The following is a description of a gene set: Ventriculomegaly Human Gene Set: HP_VENTRICULOMEGALY An increase in size of the ventricular system of the brain. studied in species Homo sapiens, and this is the list of marker genes: IGF2, SCO2, TOE1, DNAH1, MARS2, D2HGDH, TMTC3, WDR26, SMC1A, LSM11, LMNB1, TBC1D24, DEAF1, XRCC2, DPH1, SEC31A, CTNNB1, TRIP13, ZNF292, GON7, TUBB2A (NCBI Gene Id 92919), UBE3B, BRCA2, KIAA0753, IDH1, RAD51, SPRED2, SHANK3, BMP4, PLAA, MAB21L1, NPHP3, RPGR, WASHC5, C12orf57, ACTA2, CDC42, NDN, ATP11A, GFM2, CCDC39, CSGALNACT1, TAOK1, COASY, CLCN3, POLR1A, SLC31A1, SIM1, WLS, PCDH19, HRAS, CASK, GAS2L2, NCAPD3, FANCC, DNAAF1, FBXO28, TUBG1, SPEN, NDE1, GRIA3, TRIM71, ATP6V1B2, PTCH1, FBN1, TAF6 (TATA-box binding protein associated factor 6), AKT3, WDR73, FGFRL1, KCNQ1OT1, SMARCC2, TAF8, TBC1D2B, NHLRC2, EIF4A2, RNU4-2, ODAD4, RAD21 (NCBI Gene Id 5885), PUM1, OSGEP, PMM2, SNORD115-1, TET3, RNASEH2B, SATB1, FLII, USP18, NCAPG2, ERCC4 (ERCC excision repair 4, endonuclease catalytic subunit), ASPM, CEP152, PIGB, CHD7, FGFR3, CCNO, TMEM237, SLC20A2, HTRA2, CARS1, TIMMDC1, LETM1, SHH, ZBTB20, NAXE, PRNP, SOX9, EXT1, DAG1, TGDS, L1CAM, IFT140, AHI1, FH, CYFIP2, JAM2 (NCBI Gene Id 58494), KLHL15, SIN3B, ATP6V1E1, SON, SMG9, FARS2, GABBR2, NFIA, COG8, INTU, IQSEC2, SMARCB1, FOXF1, SPAG1, TRAPPC10, STAC3, CC2D2A, PIK3CA, ZMIZ1, RXYLT1, FKTN, SOX4, SLC32A1, EIF2B5, DPYSL5, RNF113A, OFD1, PIGA, NFIB, MID1, B4GALT1, DHCR7, ERCC3, MEF2C, POMGNT1, YARS1, CFAP74, C2CD3, ODAD3, FLVCR2, AHCY, HERC1, B9D1, NIPA2, NME8, NRCAM, RAD51C, SPG11, METTL5, HSPG2, VPS37A, HYDIN, PDGFRB, SLC9A6, POLRMT, NAXD, MBTPS2 (membrane bound transcription factor peptidase, site 2), FANCG, BCOR, TSEN2, DNA2, ODC1, KDM6A, PUF60, TXNDC15, NEK1 (NIMA related kinase 1), YME1L1, KRT5, CASZ1, NSD2, DHX9, FANCB, MCPH1, SMC3, ERCC2, COG1, ERCC8, ASXL3, POLR3A, DNAI2, FANCE (FA complementation group E), RAB3GAP2, PSAT1, TSEN54, BCAP31, LAMA1, RPGRIP1, KANSL1, RSPH4A, DKC1, TSFM, HTT, GJB2, INTS11, ABCD1, KCTD1, PMPCA, PUS7, CHD4, APC2, PSAP, TMX2, PI4KA, FANCM, ROGDI, CELF2, MAD2L2, PLOD3, DYNC2I1, DCHS1 (dachsous cadherin-related 1), TTC5, FIG4, IFIH1, PAX6, LIPT2, NDUFB11, COPB2, PPP2R1A, RPS6KA3, PHGDH, NDUFS2, GNAO1, EZH2, ANKRD11, NRAS, RAB18, TBK1, KRT14, EHMT1, MTHFS, HNRNPK, RAI1, FGFR2, TSEN34, MAGEL2, TRPS1, GCDH, GLB1, ZNF462, CFAP298, BLTP1, HDAC8, ACD, GJB6, DHCR24, MYMX, GOSR2, EBP, KAT8, CPT2, TCTN3, CEP290, PAFAH1B1, CTSF, RNU4ATAC, TUBB3, MPDU1, TAPT1, RTTN, GRM1, TNFRSF11A, DOK7, IFT43, SV2A, ATP1A1, TMEM138, SETD2, UBE2T, TSEN15, MYCN, MCM7, PDHX, SLC25A19, CEP63, MTOR, SEPSECS, KANK1, SASS6, ZNF148, MINPP1, ERCC5, OTUD6B, TAF13, SPEF2, NDST1, VPS13A, STRADA, KIDINS220 (NCBI Gene Id 57498), COL4A1, MAST1, PIGQ, PLCH1, LUZP1, BUB1B, RAP1B, WARS1, ACTB, TMEM216, MCIDAS, COX16, HECW2, PYCR2, POMK, WDR45B (WD repeat domain 45B), MSL3, INPP5E, GLI3, NIPBL, IFT80, ESCO2, TRAF7, GRIN1, NAE1, SIN3A, KIF26A, NSD1, ZIC1, KCNN2, SMO, KNSTRN, SHMT2, ARX, RAC3 (Rac family small GTPase 3), BRIP1, TARS1, YIPF5, POGZ, GRIK2, PI4K2A, HIBCH, ATP6V0A2, MAX, SOX11, BRF1, PRDM16, COG5, ZIC2, CCDC174, CHD8, DNMT1 (NCBI Gene Id 1786), SETBP1, DNAH9, CRB2, PLG (NCBI Gene Id 90749), TNPO2, BMP2, AMPD2, YY1, GMPPB, SUCLA2, CENPE, TERT, GTF2E2, OSTM1, DPF2, EBF3, LMNB2, USP9X, MKRN3, MYORG (NCBI Gene Id 57462), PWAR1, SLC35A2, TRPM3, ATXN3, TNNI3, RPGRIP1L, IFT172, SUMF1, NIPA1, FANCL, ALG12, COG6, TUBA1A, THOC2, OGDH, LRRC32, ZBTB11, B3GALNT2 (NCBI Gene Id 148789), NAA80, CDK10, ALDH6A1, DYRK1A, UBTF, NPAP1 (nuclear pore associated protein 1), FBXL4, PDE2A, GLUL, SARS1 (seryl-tRNA synthetase 1), OCLN, FOXP3, ARID1A, WAC, NME5, SHQ1, TRAPPC12, TAF1, POLR2A, MRE11, MTM1, KCNJ6, NAA10, COX6B1, RNU12, RERE, CEP57, BRCA1, CUX1, EVC2, OCRL, PTEN, HUWE1, DNAAF2, GNB2, KCNAB2, ADAR, TYROBP, B9D2, PTDSS1, DNAI1, DNAL1, LARGE1, ADGRG1, VPS53, TBL1XR1, GTF2H5, ZMYND10, ASXL2, COL18A1, TRPV6, ATP6AP2, TPRKB, KMT2C, KRAS, KIF5A, LONP1, HYLS1, FTO, AARS2, MTHFR, DPM1, DNMT3A, SMARCA4 (NCBI Gene Id 6597), CFAP300, CLXN, WDR81, CCDC88A, ARID2, ZEB2, DNAAF4, DENND5A, DRC1 (NCBI Gene Id 92749), NUP37, EXOC2, NDUFA6, RAPSN, CDK5RAP2, KPNA3, ESAM, GPC3 (glypican 3), KIFBP, KIF7, VPS11, PARN, KMT2D, CPLX1, SLC12A6 (solute carrier family 12 member 6), CCDC88C, RNF125, DNAH11, CHST14, ITPR1, TTC12, MAF, TCTN1, DNAJB13, SLC18A3, PUS3 (NCBI Gene Id 83480), MOCS1, RNASEH2A, KNL1, RRAS2, SLITRK2 (SLIT and NTRK like family member 2), ODAD1, VSX1, KIF21A, SPTBN1, PIK3R2, ATXN1, DMPK, PHC1, OPHN1, HK1, DSE, CDK6, GABRD, MED12, DTYMK, ANKLE2, EMG1, PNKP, USP7 (NCBI Gene Id 7874), BUB3, COX20, PGAP3, FOXJ1 (forkhead box J1), CCDC40, KATNB1 (katanin regulatory subunit B1), MT-ATP6, DNAAF3, ZC4H2, RTEL1, ERCC6, KCNQ1, COL3A1, TUBB2B, FBP1 (NCBI Gene Id 2203), KMT5B, HSD17B4, FANCD2, PPFIBP1 (PPFIA binding protein 1), NADK2, CTBP1, CILK1 (NCBI Gene Id 51541), ADNP, ZNF699 (NCBI Gene Id 374879), BRD4, BUB1, TINF2, MOCS2, COL4A2, HS6ST2, VPS35L, ISCA1, NEXMIF, H1-4, DIAPH1, RSPH1, H3-3A, RNASET2, CDC42BPB, TRAPPC6B, TBCD, NEK10, MYOD1 (myogenic differentiation 1), CEP135, SKI, TCTN2, GRN, TMEM231, AARS1, KCNK4, CUL4B, FKRP, MED25, TRAIP, XRCC4, RSPH9, DDX3X, CTCF, SHPK, ODAD2, TCF4, ALG8, PGAP1, KPTN (kaptin, actin binding protein), ZSWIM6, MRPS16, PPP2R5D, SNRPN, CHD3, RAB11B, DNAAF5, POMT1, TUBB, VRK1, FANCA, AP4B1, AFG2B, AP1S2, PPP1R21, PIGN, WBP4, TREM2, MAPRE2, PRKCZ, PIEZO2, ALG2, PIGO, PWRN1, SAMHD1, CFAP221, MMP23B, LIPT1, CIT, ZNF335, CDKN1C, FBXW11, MYT1L, FAT4, IBA57, SLC25A1, RSPH3, FLI1, MAG, TMEM147, RAC1, DPH2, MYMK, ZNHIT3, DCX, PLPBP, FANCF, YWHAE, NFIX, PDHA1, PGAP2, NDUFA8, RNF213, DHX30, PCNT, TREX1, SLC39A8, RAB3GAP1, PPP2CA, EML1, XPR1, ATXN2, EOMES, SMARCD1 (SWI/SNF related, matrix associated, actin dependent regulator of chromatin, subfamily d, member 1), ALG3, DNM1, RNASEH2C, ARMC9, SH2B1, TBCK, IFT56, SEMA3E, ASXL1, DYNC2H1, WDR35, NUP88, OCA2, MPLKIP, CSF1R, CEP120, B3GLCT, EVC, GPSM2, FOXRED1, GAN, SLX4, AP4E1, ROBO1, MFSD2A, POMGNT2, PHACTR1, DOCK6, NOTCH2NLC, SLC6A9, CLTC (clathrin heavy chain), ATP6V1A, NDUFS8, TRAPPC14, GET4, WASF1, TMCO1, BICD2, VPS51, ATP1A3, STK36, TRRAP, ALDH7A1, GPC4, ACTG1, STIL (NCBI Gene Id 6491), COX8A, PDGFB, MPDZ, NUP188, GBA1, CSPP1, DNAAF6, DNAAF11, HERC2, CLCN4, RFWD3, ANTXR1, WARS2, PDPN, DLL1, PDHB, MUSK, SMARCE1, TMEM67, PPP1CB, NANS, AHDC1, CTDP1, BGN, B4GAT1, UBE4B, CCDC22, QARS1, POMT2, CCND2, ALPK3, DOHH, UGDH, SMAD2, SRPK3, TMEM107, HEPACAM, TRIM37, SNIP1, MAPKAPK5, ARHGAP31 (NCBI Gene Id 57514), MAN2C1 (NCBI Gene Id 4123), HNRNPU, DNAH5, ADAT3, TBCE, ACBD6, CRPPA, FAR1, KIAA0586, DYNC2I2, KIF14, ARID1B (NCBI Gene Id 645070), NGLY1, SNORD116-1, HDAC4, PTPN23, AP4M1, EIF2B4, FGFR1, EIF2S3, PIK3CD, WDR62, COG4, LRRC56, ACP5, MKS1, JAM3, CLP1, PALB2, RHOBTB2, OTUD5, EXTL3, GTPBP2, ASNS, FANCI, RNU7-1, MTRR (5-methyltetrahydrofolate-homocysteine methyltransferase reductase), THOC6, AFF3